Given this list of marker genes Ldlr, Chrm5, Prkcd, Chp1, Mtmr1, Enpp7, Bscl2, Apoc2, Apoc2l, Htr2b, Rab38, Acsl3, Pdgfb, Htr2c, Arf1, Adgrf5, Fabp3, Pcx, Mtmr9, Phb2, Slc27a1, Mtmr4, Nr1h4, Mtmr2, Erbb4, Scarb1, Mtmr3, Apoc1, Lpcat1 (lysophosphatidylcholine acyltransferase 1), Idh1, Scp2, Mfsd2a, Spata18, Dnajc19, Htr2a, Capn2, Gnb3, Pdgfa, Abca2, Abca3, here is a description of the gene set: studied in species Mus musculus Mouse Gene Set: GOBP_REGULATION_OF_PHOSPHOLIPID_METABOLIC_PROCESS Any process that modulates the frequency, rate or extent of phospholipid metabolic process.